Given this list of marker genes ECHDC3, SORBS1, PRKCZ, C1QTNF12, NR1H4, SNX5, OSBPL8, ADIPOR1, PTPN11, PTPN2, SERPINA12, INS, IRS1, SIRT1, GKAP1, ERFE, PTPN1, CTSD (cathepsin D), PAK1, IGF2 (NCBI Gene Id 492304), MYO1C, ZBTB7B, NUCKS1, SORL1, LEP (NCBI Gene Id 3952), here is a description of the gene set: Human Gene Set: GOBP_POSITIVE_REGULATION_OF_CELLULAR_RESPONSE_TO_INSULIN_STIMULUS species: Homo sapiens Any process that activates or increases the frequency, rate or extent of cellular response to insulin stimulus.